Given this list of marker genes ART5, ADCY2, WFDC1, THBS2, ZFAND5, MACO1, ESAM, FBXO11, MGAT3, PPP1R3D, CASQ2, THOC6, FOXP2, DYRK1B, RHOB, EXTL1, PTCHD4, PURA, CELF4, LRRC20, SLC32A1, HJV, RTL9, CASK, FITM1, FOS, H4C1, PDLIM5, FOXP1 (forkhead box P1), RTBDN, ANKMY2, MFGE8, VCPKMT, SLC26A6, STAC, MGST3, GABRB2, SEMA7A, RUNDC1, BNC2 (NCBI Gene Id 54796), CRTAP, HOXB7, ADAM11, TPP2, IL25, SPACA9, PPARGC1A (PPARG coactivator 1 alpha), PTPRO, RALY, DIRAS1, NBEA, PYY, NEIL3, LUZP1, ATP1B2, BCL9L, ELAVL4 (ELAV like RNA binding protein 4), GAL3ST3, HDAC7, AK8, LRRC39, PMEPA1, CPT1B, AQP1 (NCBI Gene Id 358), SYNPO2L, NDP, PHKA2, NR4A1, MYOZ2, ARHGAP36, ARPP21, TSC22D1, MLLT3, TPM2, SMARCA1, GNB4, HAPLN1, ATF3, MUSK, ASB16, PLAGL2, RASGEF1B, ATP1A2, NR2F1, HOXA11, NDRG2, CD24, ZRSR2, SLC30A1, FGF12 (fibroblast growth factor 12), ATP2A3, SMIM8, SPMIP6, AP3M1, MAB21L2, ARHGEF15, XIRP1, TNNC2, ZNF385B, FBXW11, ZC3H10, CA7, PIK3R3, JCHAIN, AMPD1 (NCBI Gene Id 270), TYRO3, MEF2C, AKR1B1, MBNL2, RAP2C, DALRD3, GYG1, IGSF9B, SV2A, POFUT1, CUX1, CAPN3, KCNN1, H3C1, CNTN1, HCFC1R1, PDE6D, ENO3, MIA2, STRADB, TRMT10A, PTPN1, COL8A1, YJEFN3, SMPX, ITGA7, SCML1, SLC2A4, TWIST1, CARNMT1, TEF, CASQ1 (NCBI Gene Id 844), MYL1, AAK1, H2AC1, SLC6A13, ARHGAP26, LZTS2, TP63, CDK8, ELK4, ALPK2, CREB1, SOX5, HIVEP1, CLCN1, XK, CTNND2, RIPOR1, GPR85, DMD, SIK2, AARSD1, NCAN, TCEA3, MEOX2, SLAMF1, ITGB1BP2, OGN, H2BC1, SHANK2, FGF16 (fibroblast growth factor 16), LYN, KPNA3, EPHA7, NEXN-AS1, ACTC1, SMARCA2, LRRTM4, CLDN14, BMAL1, LINC00670, EYA1, EFHD1, TRDN, PRRX1, JUN, OPN3 (NCBI Gene Id 23596), SLC8A3, NDUFAF3, PTCH1, HLX, NFIB, KTN1, NEK2, PPP2R3A, IRS1, HOXA3, ARHGEF38 (Rho guanine nucleotide exchange factor 38), KCNQ5, TNNI3K, TRAK2, HPGD, DLG2, NFAT5, CDC42EP3, KRT222, ADK, PYY2, AMMECR1, HSPB3, VXN, RASGRF1, TRHR, FAM81A, GRIN2B (NCBI Gene Id 2904), RFX4, ZBTB18, POU4F1, SLC25A34, DGKI, ARK2N, BZW2, KRT28, CNPY2, KCNJ9, GPC4, ARMCX6, HDAC9, LBX1, PAK6, PRMT3, SIPA1L1, USP2, PRDM1, PPP1R3A, S1PR1, TIMP2, ESR1, SSPN, CPEB4, RASGRP3, MYLK, TMEM71, NCOR1, here is a description of the gene set: Human Gene Set: MEF2_03 studied in species Homo sapiens Genes having at least one occurrence of the motif NNNNNWKCTAWAAATAGMNNNN in the regions spanning 4 kb centered on their transcription starting sites. This matches the transcription factor binding site V$MEF2_03 (v7.4 TRANSFAC).